Given this list of marker genes ZPLD1, TCF4, IGF1R, HS2ST1, ENSG00000248964, ALS2, ATP5MFP4, LRRC28, INTS7, LETR1, RPS12, TMEM156, MIR320C1, PDE7B, MREG, MAP3K7, GNS, MT-TP, TBC1D1, BCR, RAP1GAP, RASIP1, MECOM, LCDR, PECAM1, FOXO1, DDX3Y, SP1, MIR3681HG, FLOT1 (flotillin 1), IGF2BP2-AS1, GORAB-AS1 (GORAB antisense RNA 1), LINC00652, HCFC1R1, MIR4521, ZC3H13, MEIS1, DYNC1LI2, RNU7-88P, ARHGEF7, TRIM22, ALKBH8, C18orf32, AGBL5 (AGBL carboxypeptidase 5), BOLA2P1, XPNPEP3, SLC38A4-AS1, STRN4, ANKRD13A, CAVIN2-AS1 (NCBI Gene Id 105373813), LINC02324, LINC00964, RPL7AP47, UCHL3, NME7, PNO1, SLC35G2, SLX4IP, STAT1, SLC25A19, EPS15L1, ERAP1, IFTAP, SPCS2, NEK6, GINM1, SSR3, CRIPTOP2, ENSG00000233461, DDX31, RN7SKP11, ZNF576, LINC02524, MBNL1-AS1, SNORD65, DCAF6 (NCBI Gene Id 55827), NSUN2, SH3BP4, FARS2, RABGGTB, FRMD6-AS2, HBP1, LINC02366, AKAP13, PDE4B, PRICKLE2-AS3, FKBP7 (NCBI Gene Id 51661), H3C9P, HEXIM1, MIR99AHG, ZNF585B, SLC7A11-AS1, RGS4, RPS23, RN7SKP271, ETV6, TAF15, UACA, CFAP418, ANP32E, ALOXE3, SPAG7, ARHGDIB, ANXA1, SNORD101, PPP1R16B, CCDC138, ZNF335, UFM1, ENPP2, NUCKS1, DLGAP1-AS2, MRPL11, RNU6-1299P, CRY2, TPM1, CALD1, LINC02332, TBL1XR1, WNT2B, MIR100HG (mir-100-let-7a-2-mir-125b-1 cluster host gene), KDM3A, TPM1-AS, HNRNPA1, EMSY, ARID1B, MIR7111, NME6, MKKS, COMETT, GNA14-AS1, FAM187A, GARIN5B, ARHGAP11B-DT, NAV2-IT1 (NAV2 intronic transcript 1), AXDND1, NHLRC3, DARS2, GAN, TNIK, ZSCAN9, HLA-DMA, PTK2, RNU2-17P, TSPAN31, CASP10, COL4A5, RN7SKP225, COPS8, POT1 (NCBI Gene Id 25913), COX7A2L, MIR31, GOSR2-DT, RPL27P8, ARHGAP26, LIG1, SEMA4A, STARD13, ZNF225-AS1, MARCHF4, GIN1, TNFSF4, NDUFA4, RBM39, ICE1, NCLN, SEC61B, ATP6V1G1P6, C6orf52, RPL36AP44, IER3-AS1, NREP, TNFRSF10B, PES1 (pescadillo ribosomal biogenesis factor 1), NDUFB3, GGA3, VCPIP1, CXCL8, FRMD3, GPRASP3, C19orf48P, LINC02458, EPHA4, GRPEL2, CRIM1, ANAPC7, MYLK, G2E3, DHRS9, COL4A6, ENSG00000267764, ANKRD50, LINC00426, RPL23AP82, PSMD6-AS1, GFOD2, RPL7P41, ZNF225, SUCO, CEP95, LINC02577, MIR3193, BUD31, DLC1, TMEM50A, CLHC1, SRSF3 (NCBI Gene Id 6428), PCSK1, SMAD3-AS1, NUP35 (nucleoporin 35), ZNF271P, COMMD1, HSPA9, UBN1 (ubinuclein 1), ARHGAP24, METTL9, MGP, CEP76, BLM, EIF4ENIF1, CAPRIN1, DDX39B-AS1, STAM-DT, POLG2, MACF1, UCK2 (NCBI Gene Id 7371), ENSG00000187951, ENSG00000223881, NBPF1, SNORD45C, SELENOF, CS, CP, GPR21, VPS50, IL1RL1, RSRP1, DZANK1, MIR4258, VMP1 (vacuole membrane protein 1), MRPS22, AP3M1, TCAM1P, SLFN12, TTC8, CCT4, STK38L, RPL23AP7, RPL35A, GIMAP1 (GTPase, IMAP family member 1), IQCG, PEX26 (NCBI Gene Id 55670), PRPSAP1, HMGN4, ARHGAP11A, CIAO2A, RABL2A, NCOA7, RNF25, TIGAR, MBTPS1, TNFRSF19, H2BC21, ESM1, PROSER1, TSN, CCSER2, ZSCAN26, USP17L24, PCDH18, PTGES3, CEP128, CENPL, RIN2, RPL31P47, CKS1B, REXO1, ZEB2, SEC24C, ALG2, ENSG00000236098, RAPGEF2 (NCBI Gene Id 9693), FN1, HRG-AS1, THBS1, NR3C2, H3C6, KLHL4, MANCR, VTI1B, NUP85, CHD9, ATP6AP1L, LINC02918, FRRS1, NVL, MAPK13, LINC02742, HNRNPC, ST13, PLEKHG1 (NCBI Gene Id 57480), RPL22L1, RBIS, LIMA1 (LIM domain and actin binding 1), RUNX1T1, VTRNA1-1, PLS1, THBS1-IT1, EIF4G2 (eukaryotic translation initiation factor 4 gamma 2), ZNF385A (NCBI Gene Id 25946), ATP5MC1P3, YBX3 (Y-box binding protein 3), TPD52, ITGB5, GAS5-AS1, MGLL, UROD, MAPKAPK5-AS1, OTUD4, SMC4, VPS37A, GOSR2 (NCBI Gene Id 9570), RABGAP1, RPS27A, ACTR3, TEX53, ROCK1P1, STEAP2, INSYN2B, ADK, CCNB1IP1, DIAPH1, UBE2E1, CSNK1G3, ABLIM1, C19orf38, ACTR10, ZRANB2, BBS4, RAB7A, KMT2A, TSNAX-DISC1, NPHP3 (NCBI Gene Id 27031), MUC20-OT1, MAP3K13, HDGF, ZNF510, RPS29P16, WASH3P, SMG6, COG4, ENSG00000261195, SNRPN, AGBL5-AS1, TRIM41, ZNF383, HHIP, MTCO3P12, YAP1 (NCBI Gene Id 10413), RWDD1, PPP6R3 (NCBI Gene Id 55291), TPP2, FBXO38, PRKAR2B-AS1, KLF7, ENSG00000232995, ABCB1, HJV, STAM, RPL13AP21, STAM2, ELOVL6, SUGT1P3, DTNA, SUDS3, SLC38A2, ENAH, MBNL1 (NCBI Gene Id 9850), TSNAX, VWF, DCTN1, PI4KB, TXN, ZNF620, ATAD2B, CPNE4, LINC02427, ADAMTS3, DMTF1, ATP5MG, DNAAF10, HECW2, CYP1B1-AS1, SLC25A5P7, AIMP1, SMAD7 (NCBI Gene Id 4092), THOC6, HIVEP3, PCBP1, EMC3-AS1, GPR107, RN7SKP192, TEK, KNL1, ANXA2, SF3B3 (NCBI Gene Id 9661), MAPKAPK5 (NCBI Gene Id 8550), RPL9, CLEC3B, CALCOCO1, PLXDC1, PLSCR4, PRSS23, DUSP14, RN7SKP208, BCKDHA, PSMA3, BLCAP, ARHGAP11A-DT, ENSG00000257746, LZTFL1, RPS14, FARSB, PSMD1, AZGP1P2, RRAGA, EXOSC5, DYNC1LI2-DT, SRRM5, SKP1, MYL12A, LINC01132 (NCBI Gene Id 100506810), BCL9, ERG, ASXL1, RGS5, TGIF1 (TGFB induced factor homeobox 1), SEC14L1, PPIP5K2, TPTE2P5, GINS4, BAG6 (BAG cochaperone 6), PDAP1, C4orf33, FOXP1, RSL24D1, VSIG1, PPWD1, RUFY1, ZRANB2-DT, EMC3, VARS1, LINC02098, CARD16, PRKCH, NFIB, MAT2B, ARID1A, SLC35B1, DNAJC24, MIR4477A, VDAC2, RBBP5, RPS26P43, TMED1 (NCBI Gene Id 11018), ADAMTSL1, LINC02029, NDC1, PKIG, RHEB, PSMG2, SEMA3A, PCBP1-AS1, BMPR1B, NEAT1, MFSD11, STK17A, SMURF2, STK36, MRPS7, PIN4, BANP, ZFYVE1, FAM237A, HNRNPUL1, LYRM4, NCEH1, TBCK, RNF182, GORAB, FEZ2, RNU6-1300P, NUP205, PAK1IP1, FGF7, PRCC, PACSIN2, ZBTB20, LINC02547, PDE11A, LINC00475, C2CD4B, ENC1, NCBP2L, HADHB, CSE1L (chromosome segregation 1 like), SRSF11, GIMAP1-GIMAP5, TBRG1, CMSS1, HADHA, DPF3, IFRD1, TM4SF1, SNORD84, CACTIN, POLR3F, NFKBIZ, TRAPPC3, CA13, ISG20, NXN, SAMD4A, TRPM3, DIAPH1-AS1, RABL2B, TM4SF1-AS1, FAM13A, TAF1D, WWTR1 (NCBI Gene Id 25937), TMEM144, MT-TF, LINC-PINT, BOLA1, ZNF839, OR10J6P, RPL21, BACH1, CMAHP, SNORA30B, ARHGAP18, NUF2, UBE3B, PJA2, IPO13, DAW1, LRRC40, CCDC103, ATF7-NPFF, SUCLG1, ABRAXAS1P1, LINC01013, MRPS33, EPCAM-DT, SUPV3L1, IRGQ, PTPRR, CTNND1, PTX3, MT-RNR1, HYCC2, SRD5A1, UPF2, DDX39B, ETV7-AS1, LINC02530, SMC2, PPP1R11, H4C8, SEPTIN11 (NCBI Gene Id 55752), ST7-AS2 (NCBI Gene Id 93654), ABCC2, TSC22D3, EFTUD2, RND3, HECTD3, TTN, CARD8, MIR181A1HG (MIR181A1 host gene), RCC1, MINCR, here is a description of the gene set: from publication Yevshin I, Sharipov R, Kolmykov S, Kondrakhin Y, Kolpakov F (PMID 30445619) studied in species Homo sapiens Human Gene Set: HMGB2_TARGET_GENES Genes containing one or more binding sites for (HMGB2) in their promoter regions (TSS -1000,+100 bp) as identified by GTRD version 20.06 ChIP-seq harmonization.